The following is a description of a gene set: Human Gene Set: HERNANDEZ_MITOTIC_ARREST_BY_DOCETAXEL_2_DN from publication Hernández-Vargas H, Palacios J, Moreno-Bueno G (PMID 17099726) studied in species Homo sapiens Among microtubule-targeting agents, docetaxel has received recent interest owing to its good therapeutic index. Clinical trials have underlined its potential for the treatment of advanced breast cancer, although little is known about its molecular mode of action in this context. We characterized the molecular changes induced by docetaxel in two well-known human breast carcinoma cell lines. Two mechanisms of action according to drug concentration were suggested by a biphasic sensitivity curve, and were further validated by cell morphology, cell cycle and cell death changes. Two to four nanomolar docetaxel induced aberrant mitosis followed by late necrosis, and 100 nM docetaxel induced mitotic arrest followed by apoptosis. Passing through mitosis phase was a requirement for hypodiploidy to occur, as shown by functional studies in synchronized cells and by combining docetaxel with the proteasome inhibitor MG132. Transcriptional profiling showed differences according to cell line and docetaxel concentration, with cell cycle, cell death and structural genes commonly regulated in both cell lines. Although p53 targets were mainly induced with low concentration of drug in MCF7 cells, its relevance in the dual mechanism of docetaxel cytotoxicity was ruled out by using an isogenic shp53 cell line. Many of the genes shown in this study may contribute to the dual mechanism by which docetaxel inhibits the growth of breast cancer cells at different concentrations. These findings provide a basis for rationally enhancing docetaxel therapy, considering lower concentrations, and better drug combinations. Genes down-regulated in MDA-MB-231 cells (breast cancer, mutated TP53) undergoing mitotic arrest and apoptosis after treatment with 100 nM docetaxel., and this is the list of marker genes: EGFL7, TAT, GALNT3, CDH1, PPP1R3F, SPRY1, CCN1, MST1R, A2M, ZNF232, NCS1, VCAN, FXYD3, SCD, TGFBR3, MST1L, EGR1, ITGB2